The following is a description of a gene set: studied in species Homo sapiens Angle formed by the plane of the ear and the mastoid bone greater than the 97th centile for age (objective); or, outer edge of the helix more than 2 cm from the mastoid at the point of maximum distance (objective). Protruding ear Human Gene Set: HP_PROTRUDING_EAR, and this is the list of marker genes: B4GAT1, SPTBN1, PUS7, TET3 (tet methylcytosine dioxygenase 3), GTF2IRD2, BUD23, POMT1, CLCNKB, TRAIP, EDNRA, ANKRD11, POU3F3, NF1, TAF1, BAZ1B, RYR1, FBXO11, SMPD4, DOCK6, CTCF, ZNF462, H19, VPS37D, SH3PXD2B, LRP4, KDM5C, EIF4H, FGFR1 (NCBI Gene Id 84151), MED12, B3GALNT2, NAA80, AHDC1, CLTC, FOXG1, GTF2H5, FAM20C, RPL10, DPP6, PYCR2, DSE, COL3A1, ZDHHC9, NECTIN1, CHRNA7, GJA8, TXNL4A, NDST1, ATP6V1A, B3GLCT, BIN1, MBTPS2, TGFBR1, MYMX, NHS, KMT2D, FRMD4A, TPM2, CAMTA1, WNT7A, DCAF17, TBX4, FKRP, MYH3, NAA10, PSMB10, COL6A1, RFX7, PPP1R12A, POMGNT1, LMNB1, PRUNE1, GJA1, PYCR1, OBSL1, POLA1, CLCNKA, FMR1, METTL27, SCARF2, TNNI2, GJB4, WDR19, DHX37, EIF4A3, AARS1, IFT56, DYRK1A, KCNK9, LIMK1, CCDC8, FKBP6, DNAJC30, KCTD1, SKI, CUL7, CCDC32, SRCAP, JARID2, PTPN11, TUBGCP4, NCF1, SLC4A10, INTS1, ARX, SLC1A4, ERCC2, MAPK8IP3, GTPBP2, PACS1, WBP4, FLNA, TP63, TRMT1 (tRNA methyltransferase 1), EBF3, OTUD6B, PQBP1, LGI4, GABRA3, FBN1, RXYLT1, BSND, NSRP1, HEATR3, MBD5, LARGE1, UBA2, NEK1, ALDH18A1, GTF2IRD1, NDP, TTN, RNF113A, BICRA, ANTXR1, CRPPA, SON, TASP1, OCRL, SMC5, PGM2L1, TFAP2B, EYA1, FIBP, TUBGCP6 (tubulin gamma complex component 6), FBLN5 (NCBI Gene Id 11268), ADNP, PI4K2A (NCBI Gene Id 55361), NR2F1, IFT122, ELN, SPIN4, SPEG, SPOP, TBL2, COL4A1, BMP1, KNSTRN, RFC2 (replication factor C subunit 2), POMT2, INSR, ERCC3 (NCBI Gene Id 2071), NSD2, POMK, RNU4-2, TMEM270, LIG4, GJA5, PLK4, POMGNT2, GTF2E2, KIF11, TP53RK, CARS1, CAMK2G, RPS6KA3, FN1, GTF2I, KDSR, NALCN, COL2A1, MEGF8, BMP4 (NCBI Gene Id 652), DLX4, TARS1, DAG1, TUBGCP2, GJB3, PIK3CD, FBXL4, IGF2, APC (NCBI Gene Id 324), RAD21, MAB21L1, EXT1, AP1S2, KANSL1, NSUN2, FIG4, CLIP2, PAX1, BLM (BLM RecQ like helicase), STX1A, MPLKIP, KDM6A, ZNF407, PIEZO2, NKAP, SHANK3, UPF3B, HNRNPK (NCBI Gene Id 3190), TBX22, CHST14, RB1 (RB transcriptional corepressor 1), FKTN, CREBBP, SIN3A, TNNT3, WNT4, HUWE1, CEP295, TRPS1, CLCF1, EDEM3